The following is a description of a gene set: studied in species Mus musculus Mouse Gene Set: GOCC_ELONGIN_COMPLEX A transcription elongation factor complex that suppresses RNA polymerase II pausing, and may act by promoting proper alignment of the 3'-end of nascent transcripts with the polymerase catalytic site. Consists of a transcriptionally active Elongin A subunit (about 100 kDa) and two smaller Elongin B (about 18 kDa) and Elongin C (about 15 kDa) subunits., and this is the list of marker genes: Epop, Elob, Eloc, Elobl, Eloa